The following is a description of a gene set: Any abnormality of the second metacarpal bone. species: Homo sapiens Human Gene Set: HP_ABNORMAL_2ND_METACARPAL_MORPHOLOGY Abnormal 2nd metacarpal morphology, and this is the list of marker genes: BMP2, GLI3, SALL1, GDF5, BMPR1B, RUNX2